The following is a description of a gene set: Genes predicted to be targets of miRBase v22 microRNA mmu_miR_7092_3p in miRDB v6.0 with MirTarget v4 prediction scores > 80 (high confidence targets). species: Mus musculus from publication Chen Y, Wang X (PMID 31504780) Mouse Gene Set: MIR_7092_3P, and this is the list of marker genes: Zfp108, Trpm3, 4930558K02Rik, Vmn1r8, Myo9a, Vldlr, Vps4b, Eps8, Ulk2, Depdc1a, Stxbp3, Hyal4, Zfand4, Zfp462, Resf1, Tfr2, Nup62, Rapgef6, Mettl21e, Zfp800, Rev1, Nt5e, Tcf12, Ust, 5031439G07Rik, Etaa1, Teddm3, Meis1, Pappa, Lrrc4, Gm7694, Vmn1r71, Ehmt1, Crls1, Armh4, Ctsk, Gjb6, Fn3k, Fam161a, Crisp2, Gng2, Asb3, St3gal2, St3gal5, Tulp2, Mbnl1, Klhl31, Cd86, Sel1l3, Nek4, Sema3a, 0610030E20Rik (RIKEN cDNA 0610030E20 gene), Tifa (TRAF-interacting protein with forkhead-associated domain), Thap2, Mybl1, Zfp967, Hnrnph2, Slco5a1, Etfa, Potegl, Als2, Rnf113a2, Ctdspl, Prkrip1, Fsbp (fibrinogen silencer binding protein), Npy1r, Hs3st3a1, Entpd1, Zfp97, Plekha3, Zfp931, Itga6, Wnt5a, Csnk2a1, Setd2, Camta1, Ccdc50, Rasgef1a, Samd13, Cdc7, Lgr5, Shtn1, Aifm2, Vps26b (VPS26 retromer complex component B), Zfp704, Trim32, Matr3, Haus6, Zfp936, Lypla1, 4833420G17Rik, Lin28b, Syne1, Miga1 (NCBI Gene Id 99746), Abhd18, Optn, EU599041, Cd3d, Ppp2r5c, Cacna1a, Fndc8, Arx, Ino80d, Foxf1, Zfp960, Cdc5l, Dmtf1l, 2210418O10Rik, Oaz2, Psme4, Fam210a, Txn2, Golga4, Zfp1008, Casp12, Pdf, Sos1, Fpr1, Wdr7, Npat, Dlat, Mylk4, Kmt5b, Gpm6b, Il1r1, Kcnab1, Zfp966, Grik2, Sh3bgrl, Gramd4, Dnajc28, Star, Tent2, Foxg1, Mlycd, Scamp1, Gm14296, Dpcd, Hus1, Cgref1, Clint1, Dop1a, Qser1, Pla2r1, Marchf5, Hapln1, Gli3 (NCBI Gene Id 14634), Ccnj, Iqsec3, Ddi2, Mrpl17, Ptpn21, Zfp971, Zfp935, Caps2, Antxr1, Tsc22d2, Zfp951, Serpinb5, Myo15a, Il22, Ift81 (NCBI Gene Id 12589), Nsun6, Akap12, Lrrtm2, Adamts1, Ppp1r1c, Vgll3, Gja8, Wwox, Gm6712, Tfrc, Creb5, Lama3, Mfsd14a, Osbpl8, Zfp1009, Tectb, Ep300, 9530002B09Rik, Baz1b, Adra1b, Pdhx (pyruvate dehydrogenase complex, component X), Mc3r, Zswim6, Pde1c, Azin1, Gabra1, Map1b, Zfp120, Cfap43, Ikzf3, Zfp599, Mageb5b, Tmem54, Ttc39b, Lpar1, Srd5a1, Fam243, Lysmd2, Strbp, Arhgef12, Eea1, Idh3a, Cyp2c50, Grik5, Rnf6, Ranbp1, H2-Ob, Arfgef2, Fbrsl1, Ebna1bp2, Gpr180, Celf4, Tex16 (testis expressed gene 16), Bbs4, Fbxo33, Sprr2h, Bcl11b, Gpd2, Cntln, Cops9, Zfp976, Zfp953, 5730507C01Rik, Cacng2, Zfp384, Ttc3, Nlrc3, Slc41a2, Kmt2d, Etv6, Rps6ka6, Capzb, Alg10b, Il22b, Sem1, Pabpc2, Bcl6, Slc4a4, Paxbp1, Klhl29, Dhx33, Kank2, Zfp970, Fmnl2, Pde4a, Mcf2l, Samd8, Blzf1, Ch25h, Gata6, Elk3, Creg2, Taf13, Ess2, Zfyve19, Gabpa, Gtf2h3, Dcaf1, Cdkn1a, Kras, Pik3r3, C1qtnf12, Nova1, Onecut2, Cdk12, Gucy1a2, Nom1, Syf2, Mpzl2, Acer3, Slc38a9